Given this list of marker genes FMR1, GAS1, TARDBP, RCBTB1, PDCD6IP, HAT1 (NCBI Gene Id 8520), PSIP1, UHRF1, PTPRK, POSTN (NCBI Gene Id 10631), ANP32B, SF3A3, WTAP, ID2, EMP3, ST7, YWHAB, CASP8AP2, UBE2M, HMGN2, SET, COPS3, CUEDC2, NFIB, LSM2, SNRPA, TACC3, FIGNL1, RBM3, HAUS6, LUC7L3, DTD1, APEX1, MKI67, CETN2, SMARCE1, MAP4, GAS2, AURKB, MARCKS, TGFBI, RBL1, SLC35A1, CAVIN3, RFC5, RASA1, CLCN4, SNORA57, PROS1, STMN1, LOXL1, ZNF267, IPO4, PKP4, PKD2, NOP58, RCN2, SLC38A4, TUBB2A, CPT1A, NDUFA13, NONO, ERH, GSTZ1, MRPL20, CFDP1, TOMM5, C1R, NCAM1, EMC6, DOCK7, CKS1B, ARGLU1, AURKAIP1, RARS2 (NCBI Gene Id 91066), EVL, NDN, CCNB2, SPCS2 (NCBI Gene Id 9789), NNT, TUFM, AMD1, PBRM1, CXCL12, DNAJC13, HNRNPL, NR2F2, H2AZ2, GTF2I, NAA38, NR2F1, HMGB2, TRIP13, CDC20, CALM3, CAPG, PSMD6, ANP32E, RSRP1, IRAK1, IVD, PRIM1, MET, B9D1 (B9 domain containing 1), NUP35, U2AF2, SLBP, AHCY, PRELID1 (NCBI Gene Id 27166), SLIRP, UBE2E3 (ubiquitin conjugating enzyme E2 E3), ECH1, H2AX, PSMB5, NUP88, CKS2, ELOF1, CETN3, PPA2, CYP1B1, CDK4, TOPBP1, FOXG1, STRAP, HSPA4, INCENP, WLS, GJA1 (NCBI Gene Id 7953), CD34, GCAT, NFKB1, KIF23, EHMT2, PTOV1, CSTF3, ANAPC5, PCLAF, CHRAC1, SFRP2, NCBP2, GSDME, KIF11, TTK, MRPL48, TYMS, PCDH7, RPA2, COL6A2, ILF3, PLAGL1, ECT2, RRM1, SERF2, FKBP4, LSM3, CARM1, RACGAP1 (NCBI Gene Id 94651), PPP1R7, GUSB, INTS8, NUP85 (NCBI Gene Id 83705), FSTL1, MRPS21, MRPL18, PTN, CPNE1, HNRNPA1L2, CDC25C, NFYC, PNP, TMPO, HAS2, MCM2, JPT1, ECHS1, SRSF6, ABCG2, EIF4G2, VCAN, ARL2BP, CTPS2, LAGE3, NME1, NDE1 (NCBI Gene Id 95348), RHOJ, GMNN, TIA1, KPNA2, RXYLT1, EIF1AX, POLE2, CTBP1, ODC1, HAUS3, TSEN34, NDUFB8, SPTSSA, SRSF1 (serine and arginine rich splicing factor 1), LARP7, MCM4, P3H3, PSMC3, PRIM2, HELLS, here is a description of the gene set: from publication Pal S, Vishwanath SN, Erdjument-Bromage H, Tempst P, Sif S (PMID 15485929) Human Gene Set: PAL_PRMT5_TARGETS_UP Protein arginine methyltransferases (PRMTs) have been implicated in transcriptional activation and repression, but their role in controlling cell growth and proliferation remains obscure. We have recently shown that PRMT5 can interact with flag-tagged BRG1- and hBRM-based hSWI/SNF chromatin remodelers and that both complexes can specifically methylate histones H3 and H4. Here we report that PRMT5 can be found in association with endogenous hSWI/SNF complexes, which can methylate H3 and H4 N-terminal tails, and show that H3 arginine 8 and H4 arginine 3 are preferred sites of methylation by recombinant and hSWI/SNF-associated PRMT5. To elucidate the role played by PRMT5 in gene regulation, we have established a PRMT5 antisense cell line and determined by microarray analysis that more genes are derepressed when PRMT5 levels are reduced. Among the affected genes, we show that suppressor of tumorigenicity 7 (ST7) and nonmetastatic 23 (NM23) are direct targets of PRMT5-containing BRG1 and hBRM complexes. Furthermore, we demonstrate that expression of ST7 and NM23 is reduced in a cell line that overexpresses PRMT5 and that this decrease in expression correlates with H3R8 methylation, H3K9 deacetylation, and increased transformation of NIH 3T3 cells. These findings suggest that the BRG1- and hBRM-associated PRMT5 regulates cell growth and proliferation by controlling expression of genes involved in tumor suppression. Genes up-regulated in NIH-3T3 cells (fibroblast) after knockdown of PRMT5 by RNAi. species: Mus musculus